Given this list of marker genes CERS3 (ceramide synthase 3), DDB2, ALOX12B, GMPPA, SLC35C1, GJB6, HLA-B, ZEB1, UBAC2, LBR, AEBP1, TRIM44, FOXC1, ERCC4, FBN1, CRLF1, UROS, GTF2H5, BTNL2, XPA, IL23R, PERCC1, TRAPPC11, AAAS, FRG1, FGF10, AIRE, RNF113A, ERAP1, FGFR3, HLCS (holocarboxylase synthetase), XPC, NLRP3, TP63, HLA-DRB1, SMCHD1, IL12A-AS1, ERCC6, MPLKIP, HLA-DPA1, ERCC8, KLRC4, STAT4, ABCA12, FAS, ERCC3, LYZ, TGM1, CARS1 (cysteinyl-tRNA synthetase 1), PNPLA1, COL4A5, IKBKG, ERCC5, COL4A6, NIPAL4, WIPF1, AARS1, WAS (WASP actin nucleation promoting factor), C4A, CTLA4 (NCBI Gene Id 3411), DUX4, DUX4L1, PTPN22, CLTCL1, IFNGR1, PRTN3, NLRP1, UROD, TLR4, HLA-DPB1, SREBF1, MBTPS2, IL6ST, RNF125, CCR1, GJB2, MTTP, MAB21L1, GATA1, MEFV, IARS2, SCN9A, ALOXE3, GSN, DNMT3B, PLEC, ERCC2, NOD2, ZFX, ATP2A2, COL17A1, TARS1, IL12A, PAX6, EPCAM, FGFR2, SULT2B1, NTRK1, POLH, IL10, RECQL, SDR9C7, GTF2E2, here is a description of the gene set: Inflammation of the cornea. Keratitis species: Homo sapiens Human Gene Set: HP_KERATITIS